The following is a description of a gene set: Genes up-regulated in MMEC cells (myometrial endothelium) at 12 h after VEGFA stimulation. Human Gene Set: WESTON_VEGFA_TARGETS_12HR studied in species Homo sapiens There is evidence that the vasculature of different organs display different functional characteristics in response to cytokines and growth factors. The aim of this study was to use cDNA gene expression microarray to analyse changes in gene expression following stimulation of myometrial microvascular endothelial cells (MMECs) with vascular endothelial growth factor (VEGF). Primary isolates of MMECs were obtained from fresh hysterectomy specimens and purified with magnetic beads. Cells were stimulated with 15 ng/ml VEGF for 3, 6 and 12 h, and two unstimulated experiments served as controls. A total of six arrays was performed over these time-points. A total of genes were identified as up-regulated by VEGF, 19% of which (genes) have previously been reported as up-regulated by VEGF or by angiogenesis. Among the novel genes to be up-regulated by VEGF were brain-derived growth factor, oxytocin receptor and estrogen sulphotransferase. The significance of the genes identified in the physiological and pathological functioning of the myometrial vasculature is discussed. from publication Weston GC, Haviv I, Rogers PA (PMID 12200464), and this is the list of marker genes: BDNF (brain derived neurotrophic factor), SLC6A8, SGCE, MMP2, SLC49A4, SULT1E1, NNMT, MGP, TFPI2, GEM, DLEU2, COL6A3, THY1, ANKRD1, CCL2, UBD, ELN, SAT1, SP3, MEST, BGN, AQP7, CFHR1, COL1A2, FGFBP1, OXTR, SDC4